Given this list of marker genes ABRAXAS2, SMURF1 (NCBI Gene Id 730332), HSD17B11, NAA25, C11orf91, MPRIP, CRISP1, SMIM14, ZKSCAN8, NHLH1, MAGI1, SYT14, ANKRD10, ZCCHC18, ATL2, PATL1, GLIPR1L2, ZNF280C, TRAM1, PYURF, ROBO2, SFT2D3, SOST, TULP4, RMDN1, AGPS, ESPL1, TRMT1L, TJP1, ONECUT1, ASAP1, MBD1, AXL, GABRP, PLD5, WDR11, FAM120C, LHCGR, CNIH1, TMEM87A, SV2B, BCKDHB, ZFPM2, CCR1 (C-C motif chemokine receptor 1), SLC24A2, WDR75, ZMYM5, CEPT1, FYTTD1, AP4B1, TSC1, CREBBP, ALG9 (NCBI Gene Id 79796), TPR, COG6, KDM5A, KCTD20, TYW1, USP50, KCNMB2, HYAL2, SKP1, MID2, CDKN2C, RBM6, SORCS3, NDUFS5, SH3YL1, ZC3H12C, PABIR3, CBL, GNS, ZNF718, SUB1, GTPBP10, ZFAND3, USP14, NCOA4, SH3TC2, SIRT1, IRF4 (interferon regulatory factor 4), FAM20B, BRPF3 (bromodomain and PHD finger containing 3), STYX, PTBP2, PARN, PLXNA4, ARMC1, NCALD, NECAB1, SLC15A1, TSPAN7, SESTD1, ZNF680 (NCBI Gene Id 340252), SLC6A1, CBLB, SLC4A4, FXR1, CAV2, CADM1, ESR1, LRR1, MAP3K21, SEMA6D, RNF166, POF1B, TRPS1, GABBR2, CLXN, SPIN3, MED10, ZNF704, NFAT5, C5orf24, NAP1L1, GID8, SMAD2, PDSS1 (NCBI Gene Id 23590), HTR2C, ATAD2B, BORCS7, FIGN, KRTAP2-1, DLST, ARL8A, KITLG, CELF1, ITIH5, GCSAML, SENP6, XKR6, ZNF516, RRP15 (ribosomal RNA processing 15 homolog), GTF2E1, EEIG2, ZNF706, FAM229A, PLN, GJA3, USP3, GID4, ZSCAN31, ARF6, ACVR1C, DPH3, DLG3, HSD17B4, OSGIN2, FNIP1, FGFR2, CDK13, BRWD1, YPEL2, SEMA6A, C5orf47, TRIM33, TYW1B, GRID1, ALOX5, ZNF236, LBH, MAGEB3, AMD1, ARHGAP11A, DCX, KRT10, CAV1, RABGGTB, JCAD, HVCN1, ORC5, KRT26, UBE3A, FLRT3, TFCP2L1, ARID1B, PTPRO, PRKCE, PCYT1B, PELI1, ARHGAP5, FAM168A, CRYM, MINDY2, TMEM14C, WASHC5, FOXK1 (forkhead box K1), SIK3, TRHDE, PAN2, FANCD2, SLC6A13, KIF1B, IRGQ (immunity related GTPase Q), here is a description of the gene set: from publication Chen Y, Wang X (PMID 31504780) Human Gene Set: MIR4773 Genes predicted to be targets of miRBase v22 microRNA hsa-miR-4773 in miRDB v6.0 with MirTarget v4 prediction scores > 80 (high confidence targets). studied in species Homo sapiens